Given this list of marker genes GNG5, GNB3, GNG8, GNG3, GNG11, GNB1, GNG7, GNG10, ARHGEF6, GNGT2, GNB4, GNGT1, GNB2, GNG12, GNB5, GNG13, CDC42 (cell division cycle 42), GNG2, PAK1, GNG4, here is a description of the gene set: Human Gene Set: REACTOME_G_BETA_GAMMA_SIGNALLING_THROUGH_CDC42 studied in species Homo sapiens G beta:gamma signalling through CDC42